Given this list of marker genes TNFRSF11B, ST3GAL5, TNFRSF6B, TNC, TJP3, LAMB1, ICAM1, PPP1R3D, AP4E1, ACE2, COL7A1, CTSZ, DOCK2, TGFB1, COL8A1, GPR162, CDC42EP3, ELN, CDK13, IFI30 (IFI30 lysosomal thiol reductase), PDGFC, P2RX3, PDGFB, PCDH7, CLMN, ACTG2, DHX9, CDK10, DKK1, STXBP2, GRIA3, CDK7, NNMT, CKS1B, TGFB2, IL21R, NRCAM, NTF3 (neurotrophin 3), IAPP (NCBI Gene Id 3375), COL6A2, CHRNA3, BDNF, CACNA2D1, RPS19, CLN8, DOT1L, RARRES1, BNIP3, PCDHB8, MAPK4, ENO1, PPARG, CD36, ITGA3, SERPINB2, COL4A6, GGTLC2, SLC6A6, BGN (biglycan), P4HA2, RHEB, SCN11A, BCL2L1, ZNF45, POSTN, ZNF460, LEFTY2, APPBP2, WNT5A, TFAP2A, LARS2, SKAP2, LEPR, HPD, FGF2, MAPK9, VCAM1, SLC29A2, TRPV2, LAMC2, C3, INSL4, NSMAF, CABP1, CSPG4, HPCAL1, RPS4Y1, CENPA, here is a description of the gene set: Up-regulated genes in the signature of adipose stromal cells (ADSC) immortalized by forced expression of telomerase (TERT). from publication Kang SK, Putnam L, Dufour J, Ylostalo J, Jung JS, Bunnell BA (PMID 15579653) Human Gene Set: KANG_IMMORTALIZED_BY_TERT_UP species: Homo sapiens Expression of TERT, the catalytic protein subunit of the telomerase complex, can be used to generate cell lines that expand indefinitely and retain multilineage potential. We have created immortal adipose stromal cell lines (ATSCs) by stably transducing nonhuman primate-derived ATSCs with a retroviral vector expressing TERT. Transduced cells (ATSC-TERT) had an increased level of telomerase activity and increased mean telomere length in the absence of malignant cellular transformation. Long-term culture of the ATSC-TERT cells demonstrated that the cells retain the ability to undergo differentiation along multiple lineages such as adipogenic, chondrogenic, and neurogenic. Untransduced cells demonstrated markedly reduced multilineage and self-renewal potentials after 12 passages in vitro. To determine the functional role of telomerase during osteogenesis, we examined osteogenic differentiation potential of ATSC-TERT cells in vitro. Compared with naive ATSCs, which typically begin to accumulate calcium after 3-4 weeks of induction by osteogenic differentiation medium, ATSC-TERT cells were found to accumulate significant amounts of calcium after only 1 week of culture in osteogenic induction medium. The cells have increased production of osteoblastic markers, such as AP2, osteoblast-specific factor 2, chondroitin sulfate proteoglycan 4, and the tumor necrosis factor receptor superfamily, compared with control ATSCs, indicating that telomerase expression may aid in maintaining the osteogenic stem cell pool during in vitro expansion. These results show that ectopic expression of the telomerase gene in nonhuman primate ATSCs prevents senescence-associated impairment of osteoblast functions and that telomerase therapy may be a useful strategy for bone regeneration and repair.